The following is a description of a gene set: Fructose metabolism Human Gene Set: REACTOME_FRUCTOSE_METABOLISM studied in species Homo sapiens, and this is the list of marker genes: GLYCTK, ALDOB (aldolase, fructose-bisphosphate B), TKFC, AKR1B1, SORD, ALDH1A1 (aldehyde dehydrogenase 1 family member A1), KHK (ketohexokinase)